The following is a description of a gene set: studied in species Mus musculus The accumulation and maintenance in cells or tissues of cholesterol, cholest-5-en-3 beta-ol, the principal sterol of vertebrates and the precursor of many steroids, including bile acids and steroid hormones. Mouse Gene Set: GOBP_CHOLESTEROL_STORAGE, and this is the list of marker genes: Ces1c, Pparg, Soat2, Lipa, Cd36, Stard4, Nr1h2, Ces1e, Ttc39d, Ces1a, Scarb1, Ttc39b, Trem2, Ces1g, Ces1d, Srebf2, Lpl, Ppara, Ehd1 (NCBI Gene Id 13660), Msr1, Ces1b, Npc1, Nr1h3, Soat1, Npc2, Ppard, Apob, Ces1h, Ces1f